Given this list of marker genes ACSM2B, ACSM5, ACSM2A, ACSM3, ACSM6, ACSM1, ACSM4, here is a description of the gene set: Catalysis of the reaction: acetyl-CoA + n malonyl-CoA + 2n NADH + 2n NADPH + 4n H+ = a long-chain acyl-CoA + n CoA + n CO2 + 2n NAD+ + 2n NADP+. studied in species Homo sapiens Human Gene Set: GOMF_FATTY_ACYL_COA_SYNTHASE_ACTIVITY